Given this list of marker genes NR5A1, RSPO1, COX7B, NDUFB11, SRY, SOX9, HCCS, WNT4, here is a description of the gene set: Human Gene Set: HP_OVOTESTIS species: Homo sapiens Ovotestis A gonad that contains both ovarian follicles and testicular tubular elements.